Given this list of marker genes AKR1C3, SERPINH1, S100A8, TNFAIP2, WFDC2, TMPRSS4, AKNA, TM9SF2, PTGER3, AKR1C1, L3MBTL4, MALAT1, ECHDC2, SMG6, LAMA4, C1orf198, CCL20, TENT5A, EEIG1, ELF3, CASP7, DAG1, NECTIN1, CA12, NSFL1C, ECE1, here is a description of the gene set: Genes up-regulated in the 5637 cell line (bladder cancer) after knockdown of E2F3 by RNAi. species: Homo sapiens Human Gene Set: OLSSON_E2F3_TARGETS_UP from publication Olsson AY, Feber A, Edwards S, Te Poele R, Giddings I, Merson S, Cooper CS (PMID 16909110) Amplification and overexpression of the E2F3 gene at 6p22 in human bladder cancer is associated with increased tumour stage, grade and proliferation index, and in prostate cancer E2F3 overexpression is linked to tumour aggressiveness. We first used small interfering RNA technology to confirm the potential importance of E2F3 overexpression in bladder cancer development. Knockdown of E2F3 expression in bladder cells containing the 6p22 amplicon strongly reduced the extent of bromodeoxyuridine (BrdU) incorporation and the rate of cellular proliferation. In contrast, knockdown of CDKAL1/FLJ20342, another proposed oncogene, from this amplicon had no effect. Expression cDNA microarray analysis on bladder cancer cells following E2F3 knockdown was then used to identify genes regulated by E2F3, leading to the identification of known E2F3 targets such as Cyclin A and CDC2 and novel targets including pituitary tumour transforming gene 1, Polo-like kinase 1 (PLK1) and Caveolin-2. For both bladder and prostate cancer, we have proposed that E2F3 protein overexpression may cooperate with removal of the E2F inhibitor retinoblastoma tumor suppressor protein (pRB) to drive cellular proliferation. In support of this model, we found that ectopic expression of E2F3a enhanced the BrdU incorporation, a marker of cellular proliferation rate, of prostate cancer DU145 cells, which lack pRB, but had no effect on the proliferation rate of PC3 prostate cancer cells that express wild-type pRB. BrdU incorporation in PC3 cells could, however, be increased by overexpressing E2F3a in cells depleted of pRB. When taken together, these observations indicate that E2F3 levels have a critical role in modifying cellular proliferation rate in human bladder and prostate cancer.